The following is a description of a gene set: Genes containing one or more binding sites for (ZNF257) in their promoter regions (TSS -1000,+100 bp) as identified by GTRD version 20.06 ChIP-seq harmonization. studied in species Homo sapiens Human Gene Set: ZNF257_TARGET_GENES from publication Yevshin I, Sharipov R, Kolmykov S, Kondrakhin Y, Kolpakov F (PMID 30445619), and this is the list of marker genes: ATMIN, MRPL24, TBC1D10B, ACVRL1, ENSG00000283078, PRPF31, ETV4, PTMS, TNFSF9, S100A1, PITPNC1, FAM219A, TMEM38B, SREK1, EIPR1, REPS1, ANKS6, WDR12, GALNS, KRT18, BRIP1, TMED1 (NCBI Gene Id 11018), DARS2, PLK3, CCNT1, DUSP22, CCDC125, STX6, MTA3, OFD1, HSF2, ATAD2B, PABPC1, GRP (NCBI Gene Id 2922), TMEM8B, MAP3K12, PRR14, PIK3R3, TRAPPC14, SPX, MIR4779, GNAI2, C15orf40, NIBAN1, MOB1A, BTNL12P, TCEANC2, MBD6, ECSIT, MEAK7, ZNF354B, PICART1, KIF20A, KIF23-AS1, ZNF271P, ZSCAN30, SCP2, METTL6, MELTF, TSFM, YPEL5, SAP30L, TRAK1, XPC-AS1, UBE2D3, PRKAB1, ENSG00000267568, AKR7A2P1, PTPDC1, EOLA1, EPB41, SDSL, CENPL, RBBP9, ARL14EP, MIOS-DT, TTLL4, IARS1, CCDC18, EPM2A-DT, QPCTL, NUP153, DBI, MIR5191, RSF1, ANKRD26, DIDO1, KRTCAP2, ILRUN, CA11, ODAD3, B9D1, KCNJ2-AS1, SHOC2, SIVA1, RANBP9, ANKRD12, BSG, H2BC15, AP2A1, ZNF740, LRRK1, TNFAIP1, CC2D2B, TFPT (NCBI Gene Id 29844), IFT20, NORAD, ARHGAP18, SLC25A45, MIR29B2CHG, PTGES3, YIPF3, SPIRE1, CATSPERG, VPS33B-DT, VARS2, ECHDC2, DEDD, NAA30, TBCB, LSG1, TMEM242-DT, HINT2, IPP, MLF2, NR2F1-AS1, SPAG5, RNF138, PTPN12, COPS7A, PSMG2, ZFP36, LINC01424, ENSG00000248636, PKP4, DZIP3, CENPN-AS1, DVL3, YWHAH, KIF2A, MTND5P11, EIF3J, LNPEP, C2CD5, TRIB3 (NCBI Gene Id 57761), ST6GALNAC2, ZSCAN9, RMND5B, GDF11, EIF3J-DT, RAB5C-AS1, CHCT1, EPS8, AGAP3, S100A13, HOOK2, FBXO30, C2orf76, AAMDC, BICDL1, GPBP1, CADM1, FHOD3, RNF167, RNF217, IRF9, FZD2, FDFT1, TBX3, PROX1, ITGB3BP, TRIM41, APRT, PARAIL, SLC12A7, ECHDC1, ZNF688, ABCD2, HJV, GINS1, CEMP1, LARS1, LINC02453, UBE2E1, SNX10, DELE1, SLCO4C1, FRMD4B, ANO8, CTC1, IRAK1BP1, ZNF391, POLR1C, TBC1D20, KIAA0319L, PRKCSH, INTS2, SMAD7, MIR4638, VPS51, BCL2L11, RPS3P3, PDP2, FOXA1, GBA1, WARS2-AS1, SELL, H4C16, EI24, ZNF584, CEPT1, TOM1, MIR3178, NUP153-AS1, PPP2R3A, FLOT1, ARIH2OS, RET, RIPOR3-AS1, STUB1, COMMD1, DENND6A, PTPN21, RGS16, TMEM200B, CFAP300, SMG5, ANO10, JAG1, LIPA, SKOR1-AS1, EAF1, CDC14B, BBIP1, SPTLC2, TRAPPC2, CCDC18-AS1, PPP1R12A-AS2, PCLAF, CHD2, HAS2, RXFP4, ATP2A1-AS1, SPINT2, PREP, GTF2H4, ABHD5, CSNK1E, ENO3, ENSG00000260086, C10orf53, CMTR2, ST3GAL5, FAM98C, PRDX1, MTCH2, C10orf88B, EOLA2-DT (EOLA2 divergent transcript), LGMN, CNOT11, PIK3AP1, NR1D1, PSMB4 (NCBI Gene Id 5692), DDHD2, KMT5C, UBR4, PLPBP, SNRPD2, FRYL, SEC61A1, EMC1-AS1, ZNF607, TCAIM, TARBP2, C17orf75, GLI2, TNKS2, VCPIP1, SPOP, TBC1D30, KDM6B, CEP85 (centrosomal protein 85), PRDM1, TRAPPC2L, STMN4, ILVBL, PPP1R37, ITPR1, GNAQ, TRIM46, HEATR5B, GFRA2, CSAD, NXNL2, HSPA6, NKX2-2, TVP23B, KIF22, ZNF566, BRD8, PTCH1, SNAPC5, STX8, CCDC71L, MIR193B, FBXO16, POLR2L (RNA polymerase II, I and III subunit L), CBFA2T2, THOC2, LINC02916, HINT1, DLK2, TRIP12 (NCBI Gene Id 9320), TSEN2, VPS35, ZNF566-AS1, USP2, SH3D21, UBE2V1, AFF1, TAGLN2, GORAB, NEDD4L, HSPBP1, DRG2, MOCS3, QSOX1, LINC01780, DENND6A-DT, SCNM1, GLIPR1, PPP1R3F, LSM14A, UBE2G2, SLC25A48, FRAS1, CORO1C, PLEKHG5, NDUFV3, USP32, BAHD1, NCDN, RPS15A, PLPP5, TSPEAR-AS1, CCND1, LYSMD1, DNM1L, KTI12, TRIP4, CHCHD2P2, RALGAPA2, MTCO3P12, S100A4, MRPL39, ABCA7, MFAP3, UBE2G1, TWF1, KPNB1, TMBIM6, GEMIN2, DDR1, DDX3P2, CRAT, TMEM59, CCSER2, KANSL2, TGFB2, HTR7P1, UBE2K, MED18, WDFY3-AS2, CRIP1P1, FLAD1, GDF15, DDIT3, ALG3, ZNF462, FGL2, G6PC3, PAWR, KIAA1586, ERFE, TMEM79, EMC10, SIAH1, GORAB-AS1, MTMR12, ZNF529, HSF2BP, TNKS2-DT, TARS2 (NCBI Gene Id 80222), ZNF549, MOCOS, CDK1, ATP23, LTBP4, MIA3, NRG2, IER3-AS1, F11R, TSHZ1, MFAP4 (microfibril associated protein 4), SETD9, LRRC58, FEZF1-AS1, ZNF345, RGMB, PDCD6IP, LINC02086, HSD17B4, DLX1, MZT1, NPAS1 (neuronal PAS domain protein 1), PAGR1, ARHGAP45, EPB41L2, NPTX2, TAF4, CCNG1, AKT1, RBBP5, SAMD4B, HOXC8, SLC2A1-DT, KLHL11, C19orf38, SZRD1, GTPBP3, SAMHD1, RPL15, BORA, GUSBP11 (GUSB pseudogene 11), BMS1, RALBP1, COQ8A, HOMER1, MRPS31P5, GADD45A, TSPAN15, CCDC47, ECI1, ARL6IP1, SULT1A1, INKA2 (NCBI Gene Id 55924), RSPO2, NFYB, DMAP1, SLC9A5, GPATCH11, TINF2, WDR89, SLC25A4, EOLA1-DT, ZNF268, PRKCH-AS1, TRAM2-AS1, RIPK2, PUM3, HIGD2B, CNN3, LRRFIP2, TMEM258, EML4, SLC2A1, BBS4, GREM2, PFAS, ZNF790, TLE4, C16orf46, ITPKB, GNPNAT1, RBM23, SUMF2, ZNF579, SPAG5-AS1, DENND4B, STAG1, RNU6-453P, SCAMP5, TMEM94, POLR2I, RANBP2, RBM33-DT, GTF2I, TFAP2A, ERBB3, ITGA3, PRMT5-AS1, TSPAN4 (NCBI Gene Id 7106), GAS2, ZSCAN16, SNCAIP, NDUFV2-AS1, TFB1M, RSL24D1, VPS33B, C3orf38, ZNF3, PACC1, ARHGEF11, GGA2, ZNF18, SLC16A1, SLC18A3 (solute carrier family 18 member A3), ZNF703, SRRM1, TDP1, NKIRAS1, TBC1D23, ZNF446, DDX42, LIX1L, PPM1N, RPL36 (NCBI Gene Id 92364), ACTG1P25, NIPSNAP3B, CREB5, TXNRD2, TMEM242, LINC00467, PROX1-AS1, FANCC, LINC00265, SNX4, ZNF440, CRLF3, FAM133B, LRCH1, SET, AIMP2, MTMR4, IPO11, ORC6, LIMA1, NEAT1, MAZ (MYC associated zinc finger protein), QSER1, SAP30L-AS1, UBE2Q1, RPS7, DNAI1, FLI1 (NCBI Gene Id 2313), PRKCA, CDH23-AS1, FBXL20, C19orf12, ZBBX, HP1BP3, SLC25A11, WDFY3, KYAT1, RBM33, SPECC1 (NCBI Gene Id 92521), GOLM2, TRAF4 (NCBI Gene Id 9618), PRPF19-DT, C16orf46-DT, GARIN5A, CARF, SUPT5H, PRPSAP1, MAPK7, NOL11 (NCBI Gene Id 25926), CYP20A1